Given this list of marker genes CDKN2A, CTNNB1, POLR3A, TP53, AR, ESR1, ZNRF3, TERT, PRKAR1A, here is a description of the gene set: Human Gene Set: HP_INCREASED_SERUM_ESTRADIOL Increased serum estradiol studied in species Homo sapiens An elevation above normal limits of the concentration of estradiol in the circulation.